Given this list of marker genes SLC1A4, SERINC5, SLC1A5, SERINC3, SFXN2, SLC7A10, SFXN1, SFXN3, SLC38A2, SLC38A5, here is a description of the gene set: studied in species Homo sapiens The directed movement of L-serine, 2-amino-3-hydroxypropanoic acid, into, out of or within a cell, or between cells, by means of some agent such as a transporter or pore. Human Gene Set: GOBP_SERINE_TRANSPORT